Given this list of marker genes CRB3, GJA1, PALS1 (protein associated with LIN7 1, MAGUK p55 family member), TJP1, PATJ, here is a description of the gene set: species: Homo sapiens SARS-CoV-2 targets PDZ proteins in cell-cell junction Human Gene Set: REACTOME_SARS_COV_2_TARGETS_PDZ_PROTEINS_IN_CELL_CELL_JUNCTION